Given this list of marker genes CDH2, NRAP, DES (desmin), ACTN1, DSP, CTNNB1, CTNNA3, VCL, here is a description of the gene set: A cell-cell junction that contains the transmembrane protein N-cadherin, which interacts with identical molecules from neighbouring cells to form a tight mechanical intercellular link; forms a large portion of the intercalated disc, the structure at which myofibrils terminate in cardiomyocytes. Human Gene Set: GOCC_FASCIA_ADHERENS species: Homo sapiens